The following is a description of a gene set: Human Gene Set: PULVER_FOREY_CELLCYCLE_ENRICHED_TFS_G1_S species: Homo sapiens Transcription factors and DNA binding proteins enriched at promoters of genes whose expression fluctuates during the cell cycle (pVal < 0.05) and peak in G1/S in K562 Transcription regulation during the cell cycle is crucial for ensuring genes are expressed at the right time and in the correct amounts, coordinating key processes like DNA replication, mitosis, and cell division. In our study,, and this is the list of marker genes: RNF2, ZBTB14, EGR2, E2F4, ZFP64, ZBTB7A, ZNF519, ZNF786, EZH2, ZNF33B, CBX2, CCNT2, ZBTB26, SP4, SP2, MAZ, L3MBTL2, RBFOX2, ZNF26, GLIS1, E2F7, UBTF, ZFX, EGR3, TFDP1, PHF8, RB1, MGA, ZNF282, CTBP1, ZNF202, NRF1, ZNF341, HNRNPLL, POLR2A, KLF15, POLR2G, ZNF783, YY1, ZNF257, EGR1, RBBP5, E2F3, E2F6, SP1, VEZF1, MAX, CXXC5